The following is a description of a gene set: Abnormal exteroceptive sensation A type of somatic sensory dysfunction characterized by abnormality of superficial sensation that is mediated by receptors in skin and mucous membranes. species: Homo sapiens Human Gene Set: HP_ABNORMAL_EXTEROCEPTIVE_SENSATION, and this is the list of marker genes: TNFRSF1A, PSAP, DKK1, NFU1, HINT1, MSH6, ADAMTS15, TWNK, WNK1, HLA-B, SNRPN, TET2, SIM1, IL23R, OCA2 (NCBI Gene Id 4948), GBE1, PEX16, ATL3, STX16, NALCN, ZFHX2, ALDH18A1, MPL, TYMP, RAI1, SPTAN1, CCT5, FMR1, SORD, POLE, TK2, CLCNKB, HPDL, DCAF8, NPAP1, UNC80, KIF5A (NCBI Gene Id 84710), SEMA4A, PRPS1, ALAD, NAGLU, SCYL1, HPGD (15-hydroxyprostaglandin dehydrogenase), TRAPPC2, PRRT2, KRIT1, CTDP1, GNB4, CLTCL1, GNA14 (G protein subunit alpha 14), SNORD116-1, UBTF, KRT9, SEPTIN9, IARS2, UBAC2, SNORD115-1, CALR, FAS, MEN1, RRM2B, TGFBR2, ABCA1, RFC1, IL10, HLA-DQB1, DSE, NTNG1, SH2B3, APP, NGF, CDKL5, TGM1, AEBP1, SPTLC2, GABBR2, PDXK, CHEK2, PMP22, KIF1A, ELP1, SPTLC1, UROD, DDHD1, FBN1, MAGEL2, MLH1, MFN2, LITAF, TLR4, DEPDC5, HK1, CCM2, PMS2, KLRC4 (killer cell lectin like receptor C4), PWAR1, MYORG, ALS2, GATA1, KCNQ1OT1, SH3TC2, RPS20, SHANK3, IFNGR1, GALC, KCNJ1, CBLIF, IL12A, OPA3, SACS, DEAF1, IL12A-AS1, NF2, TMEM218, MTRFR, ATM, SNUPN, SLC19A2, MADD, PMS1, HDAC4, ERAP1, RAB7A (RAB7A, member RAS oncogene family), GLA, COMP, GDAP1, MPV17, GJB1, MKRN3, MUTYH, PRORP, COL1A1, NDN, SLC12A3, ERLIN2, TDP1 (tyrosyl-DNA phosphodiesterase 1), SETX, FLII, GNA11, POLD1, VWA1, CACNA2D1, SRPX2 (NCBI Gene Id 27286), LIG3, SLC12A1, RFX7, SCN11A, BRCA2, KRAS, GRIN2A, TRIM32, YY1, GABRG2, CCND1, HNRNPK, EPCAM, ATXN1, DNM1L, AIP, FGD4, NGLY1, PRDM12, SDHA, HSPB1, SLC2A1, ZFTA, KDM5C, PTPN22, SCN9A, BSCL2, TP53, NTRK1, MCM3AP, ALDH4A1, NDRG1, MSH2, NLRP3, KRT1, ATP13A2, PIK3CA, EBF3, MEFV, ABCD1, MORC2, GRIA3, H19, KRT14, CHST14, PMP2, KRT5, ATL1, SMC1A, BMPR1A, RNF170, SYNGAP1, JAG1, LMX1B, NKX6-2, SERPING1, ZEB2, HERC2, MTHFR, PRNP, CUBN, SBF2, KLHL9, ADA2, PDCD10, PLEKHG4, LZTR1, THPO, NAGA, IQSEC2, RETREG1, GNAS, STAT4, DHH, AIFM1, ATP1A2, IGF2, MPZ, UROS, SCN1A, HRAS, KRT16, VCP, HARS1, HMBS (NCBI Gene Id 5448), COQ6, POLG, SLCO2A1, ATP7B, C4A, NEFL, TRIO, NPRL2, PNPT1, SMARCB1, HEXB, CASR, HLA-DRB1, PWRN1 (Prader-Willi region non-protein coding RNA 1), SCN4A, LIFR, TRPM3, CHAMP1, SLC26A2, MECP2, GPR101, PDK3, JAK2, P4HA2, NPRL3, CACNA1A, CCR1, SCN10A, NARS1